Given this list of marker genes CCR6, PTPN18, SMOX, COX16, PIGS, NINJ1, TFEB, PALD1, NF2, RAMP1, TAX1BP3, TTYH2, TP53, ZNF280C, ABCD2, N4BP3, CDC42SE1, CD300C, ATG12, DGAT1, CUL4B, ROMO1, CD93, HS1BP3, ITIH2, RASSF5, TSPAN13, RBM5, PPP3CA, ERMP1, FAM98C, URI1, GATC, ACOX1, PIGC, ISCU, PCNX3, HELZ, NDUFA10, AGR3, AVPI1, CYS1, TGFBR1 (transforming growth factor beta receptor 1), SLC12A9, TESK2, PELI2, ZNF524 (NCBI Gene Id 147807), REV3L, SMARCAL1, GDI2, SMARCA1, CYTH1, KLHL22, CCR2, FBXO25, ELOVL5, FRRS1, MGAT4B, ANKRD10, ARHGDIB, TMEM242 (NCBI Gene Id 729515), NDUFC2, SLC39A11, IAH1, FAM76A, RPS15A, VAMP8, PDLIM2, HSD3B2, METTL8, TNRC6B, ALDH1L1, SMPD2, ESCO1, PKDCC, HCFC1, COMMD6, C1orf54, TBCD, RABGGTB, CLNS1A, HMGB3, SLC40A1, TULP4, ERBB3, ZNF574, CETN2, ATG2B, ERLIN1, MYOF, STXBP2 (syntaxin binding protein 2), BPGM, PIAS2, SELENOM, PTS, DPM2, POLR3GL, ZBTB20, RASSF3, EIF3H, GLO1, MYL12B, SELENBP1, PRKACA, CORO1A, SH3BGRL3, TRIM54, DNASE2B, ZFYVE19, MCEE, ELMO2, HGSNAT, FASTKD1, MMD, CUEDC2, AIFM1, BAZ2A, ASCC1, AKR7A2, GAS2, TMEM50B, POLR1D, CERS5, YWHAH, ORMDL3, ADAM11, EBP, RHBDD3, GLUL, SLC7A7, SMC3, SLC25A20, TRIM3, PGD, CPT1A, SLC37A3, LIN37, MGAT2, TSPAN14, TGFBI, KANSL2, CYBC1, LPGAT1, CPSF1, FLCN, TBX21 (T-box transcription factor 21), SSR4, SRRD, LANCL1, GADD45G, SLC25A4, MYOZ1, SLC46A3, HCFC1R1, PTOV1, MRC1, APLF, STK38, CEP19, RNF181, ARMC6, CEBPZOS, MRPL51, CRTAP, TOMM20, PBX2, MRPL28, TPRA1, NAPB, TMEM179B (NCBI Gene Id 374395), SRF, FAM50A, ZBTB11-AS1, BAZ1B, COL6A1, PHKG2, PTPRA, SLC41A3 (solute carrier family 41 member 3), MRPL2, SOD1, KIAA0930, SARS1, GOLIM4, PLEKHA1, CTDSP1, NCKIPSD, TUBB2B, BDH1, PARK7, MANBA, PLXNB2, CCNI, ATP1B2, SERPINB4, MIEN1, ADK, FDPS, GPX4, ZNF106, CENPH, here is a description of the gene set: studied in species Homo sapiens from publication Amit I, Garber M, Chevrier N, Leite AP, Donner Y, Eisenhaure T, Guttman M, Grenier JK, Li W, Zuk O, Schubert LA, Birditt B, Shay T, Goren A, Zhang X, Smith Z, Deering R, McDonald RC, Cabili M, Bernstein BE, Rinn JL, Meissner A, Root DE, Hacohen N, Regev A (PMID 19729616) mouse primary BMDCs were stimulated with tlr ligands and gene expression changes were profiled on Affymetrix arrays Human Gene Set: GSE17721_CTRL_VS_CPG_6H_BMDC_UP Genes up-regulated in comparison of control dendritic cells (DC) at 6 h versus those stimulated with CpG DNA (TLR9 agonist) at 6 h.